The following is a description of a gene set: Not all breast cancers respond to tamoxifen, and many develop resistance despite initial benefit. We used an in vivo model of estrogen receptor (ER)-positive breast cancer (MCF-7 xenografts) to investigate mechanisms of this resistance and develop strategies to circumvent it. Epidermal growth factor receptor (EGFR) and HER2, which were barely detected in control estrogen-treated tumors, increased slightly with tamoxifen and were markedly increased when tumors became resistant. Gefitinib, which inhibits EGFR/HER2, improved the antitumor effect of tamoxifen and delayed acquired resistance, but had no effect on estrogen-stimulated growth. Phosphorylated levels of p42/44 and p38 mitogen-activated protein kinases (both downstream of EGFR/HER2) were increased in the tamoxifen-resistant tumors and were suppressed by gefitinib. There was no apparent increase in phosphorylated AKT (also downstream of EGFR/HER2) in resistant tumors, but it was nonetheless suppressed by gefitinib. Phosphorylated insulin-like growth factor-IR (IGF-IR), which can interact with both EGFR and membrane ER, was elevated in the tamoxifen-resistant tumors compared with the sensitive group. However, ER-regulated gene products, including total IGF-IR itself and progesterone receptor, remained suppressed even at the time of acquired resistance. Tamoxifen's antagonism of classic ER genomic function was retained in these resistant tumors and even in tumors that overexpress HER2 (MCF-7 HER2/18) and are de novo tamoxifen-resistant. In conclusion, EGFR/HER2 may mediate tamoxifen resistance in ER-positive breast cancer despite continued suppression of ER genomic function by tamoxifen. IGF-IR expression remains dependent on ER but is activated in the tamoxifen-resistant tumors. This study provides a rationale to combine HER inhibitors with tamoxifen in clinical studies, even in tumors that do not initially overexpress EGFR/HER2. Genes rapidly up-regulated in breast cancer cell cultures by estradiol. Human Gene Set: MASSARWEH_RESPONSE_TO_ESTRADIOL from publication Massarweh S, Osborne CK, Creighton CJ, Qin L, Tsimelzon A, Huang S, Weiss H, Rimawi M, Schiff R (PMID 18245484) species: Homo sapiens, and this is the list of marker genes: KAZN, TPD52L1, MEGF9, MYB, TMPRSS3, LARGE1, SCARB1, PRSS23, RXRA, EGR3, CXCL12, RBBP8, FLNB, FCMR, PGR, STARD13, MAPT, TIPARP (NCBI Gene Id 25976), STC1, PMAIP1, RHOBTB3, TMCO6, IRS1, ELOVL2, TSKU, GREB1, ADD3, SERPINA5, SYBU, PDZK1, SLC26A2, IGFBP4 (insulin like growth factor binding protein 4), OLFM1, TMA16, ETNK2, CA12, GLA, SLC1A4, MYOF, MAP2, CDV3, KLF10, DEPTOR, SGK3, NRIP1, SMPDL3B, IGF1R, IL17RB, LRIG1, SRI (sorcin), PSMG1 (NCBI Gene Id 8624), SOX4, MYBL1, AMFR, ZHX2, ADRA2A, TUBB2B, AREG, APTX, SIAH2, MREG, TOP2A